The following is a description of a gene set: The modification of a protein by cis-trans isomerization of a proline residue. Mouse Gene Set: GOBP_PROTEIN_PEPTIDYL_PROLYL_ISOMERIZATION studied in species Mus musculus, and this is the list of marker genes: Pin1rt1, Ppil1, Ppia, Ppib, Nktr, Ppwd1, Ppif, Pin1, Ppic, Ppie, Ppig, Ppid, Ppih, Ppihl